Given this list of marker genes Defb33, Wfdc16, Shc1, Defa26, Casp1, Slamf8, Sprr2a3, Bpifa1, Slamf9, Oas1g, Lyz3, Muc19, Sprr2a1, Rab34, Acp5, Ear2, Vip, Rnase9, Wfdc6a, Tmf1, Nod1, Fpr-rs3, Rag2, Pgc, Wfdc9, Fcer2a, Ighg2c, Nlrp6, Krt6a, Ighg3, Bpifa2, Defa39, H2bc21, Defb12, Clec4d, Prkd1, Igha, Znfx1, Hck, Ssc5d, Lta, Rnase6, Ang6, Defa42, Defb3 (defensin beta 3), Wfdc17, Fcgr1, Ikbkg, Gbp2, Mill1, Naip1, Epx, Raet1d, Zg16 (NCBI Gene Id 69036), Defa35, Gm6040, Rnase2a, Pla2g2a, Defa25, Fpr-rs7, Nr1h4, Akirin2, Tab3 (TGF-beta activated kinase 1/MAP3K7 binding protein 3), Nagk, Lpo, Rnase2b, Rnf213, Fau, Rarres2, Defb50, Elane, Rnase11, Oas1b, Spag11a, Stab1, Irgm1 (NCBI Gene Id 15944), Bpifa5, Klk7, App, Grn, Defb48, Oas2, Casp7, Defa20, Wfdc21, Ifnb1, Mmp7, Pla2g1b, Lyg2 (NCBI Gene Id 332427), Sharpin, Lyg1 (NCBI Gene Id 69541), Inhca, Fgb, Reg3g, Lalba, Tirap, Pglyrp3, Foxp1, Defa41, Gzmb, Defb7, Gsdmc2, Muc5b, Rnase12, Fpr-rs4, Aicda, Card9, Gsdma, Defb15, Il1b, Il12b (NCBI Gene Id 16160), Ppl, F2rl1, Ear10, Serpine1, Defa38, Cxcl5, Defa3, Romo1, AY761185, Defa22, Defb42, Defa37, Ifna1, Rab14, Wap, Fcer1g, H2-T23 (NCBI Gene Id 15040), Arg2, Nos2, Rasgrp4, Serpinb9 (serine (or cysteine) peptidase inhibitor, clade B, member 9), Prg2, Spn, Vgf, Defb20, Oas1d, Nfkb1, H2bc12, S100a14, Il7r, Fpr-rs6, Gsdma2, Oas1f, B2m, Defa40, Nfkbiz, Defb37, Tnfrsf1a, Emilin2, Defa29, Il23a, Defa23, Syt11, Oas1h, Defb9, Oas1e, Dao, Havcr2, Adamts5, Mpo, Defa5, Naip2, Lcn2, Defb4, Lyzl4, Clec4e, Tac1, Rbpj, Trem3 (triggering receptor expressed on myeloid cells 3), Gsdmd, Rpl39, Il10, Il17a, Pla2g6, Slc9a9, Spon2, Defb47, Trem1, Tnf, Peli3, Gbp7, Hamp2, Wfdc15b, Tlr4, Igtp, Syk, Casp4, Cd160, Prkcd, Il18, Defa28 (NCBI Gene Id 626682), Ctsg, Pycard, Defa31, Defb22, Ripk2, Evpl, Anxa3, Notch2, Mr1, Gbp4, Wfdc18, Leap2, Trf (NCBI Gene Id 22041), F2, Il33, Reg3b, Iigp1, Dmbt1, Rpl30, Defa30, Mpeg1, Ltf, Ang5, Tnfaip8, Lgals4, Rps19, Defb13, Wfdc13, Defb29, Isg15, Defb21, Epha2, Tlr2, Optn, Gbp8, Rnase10, Ear14, Mapkbp1, Tnfsf8, Naip5, Defb10, Aqp1, Mavs, Lyst, Ang4, Rnase4, Il27ra, Galp, Oas1c, Defa21, Mbl2, Rnase13, Ifne (NCBI Gene Id 230405), Umod, Defb5, Seh1l, Lyz1, Gbp6, Cyba, Abcc1, H2-K1, Defb38, Myd88, Ighe, Defa34, Defb2, Defb25 (NCBI Gene Id 654459), Pld1, Il17f (NCBI Gene Id 96930), Klrk1, Rbck1, Npy, Hamp, Defb1, Drosha, Tnfrsf14, Gbp5, Tlr9, Spag11b, Rnase1, Wfdc5, Rab1a, Scd1, Tslp, Rnf31, Chga, Pglyrp1, Cd36, Unc13b, Defb8, Adgrb1, Ppp1r11, Colec12 (NCBI Gene Id 225157), Stab2, Bcl3, Camp, Defb41, Lgals9, Slc30a1, Tab2, Pglyrp4, Defb11, Slpi, Cxcl13, Wfdc12, Gimap6, P2rx7, Ncf1, Defb39, Gpr15lg, Irgm2, Defa17, Gsdmc, Ear1, Defb6, Ifng, Defb30, Eppin, Wfdc3, Dhx15, Plac8, Defb46, Gsdmc4, Mmrn2, Cd209d, Emilin1, Defb43, Nod2, Map3k7, Cebpb, Oas3, Ighm, Lbp, Lyz2, Adm, Tusc2, Lyzl6, Fga, Ivl, Ang, Gbp9, Bpi (NCBI Gene Id 329547), Slc15a2, Cd4, Tfeb, Slc11a1, Tbk1, Jchain, Pglyrp2, Ighg1, Ankrd17 (ankyrin repeat domain 17), Gbp3, Cst11, Pfpl, Irf8, Defb19, Xiap (NCBI Gene Id 74774), Defb35, Trem2, Nlrp10, Myo1f, Hp, Gbp10, Wfdc10, H2-M3, Defb14, Ighg2b, Pten, Nlrp1a, Gbp2b (guanylate binding protein 2b), Nlrp3, Gsdmc3, Hmgb2, Defb18, Wfdc15a, Mbl1, Scnn1b, Marchf2, Lypd8, Adamts4, Wfdc11, Ang2, Pcyox1l, Defa2, Defa24, Defb36, Fpr2, Defb34, Adam17, C5ar1, Naip6, Defb40 (NCBI Gene Id 360217), Wfdc2, Gm12250, Il22ra1, Ear6, Oas1a, Nlrc4, Klk5, Fgr, Gsdma3, here is a description of the gene set: studied in species Mus musculus Mouse Gene Set: GOBP_DEFENSE_RESPONSE_TO_BACTERIUM Reactions triggered in response to the presence of a bacterium that act to protect the cell or organism.